Given this list of marker genes STAT3, NTRK1, NGF, here is a description of the gene set: Reactome Pathway: Signalling to STAT3 Neurotrophin-induced increase in Signal transducer and activator of transcription 3 (STAT3; acute-phase response factor) activation appears to underly several downstream functions of neurotrophin signalling, such as transcription of immediate early genes, proliferation arrest, and neurite outgrowth. part of: Signaling by NTRK1 (TRKA) studied in species Homo sapiens